The following is a description of a gene set: Mouse Gene Set: GOBP_NEGATIVE_REGULATION_OF_PEROXISOME_PROLIFERATOR_ACTIVATED_RECEPTOR_SIGNALING_PATHWAY Any process that stops, prevents, or reduces the frequency, rate or extent of the peroxisome proliferator activated receptor signaling pathway. species: Mus musculus, and this is the list of marker genes: Stub1, Huwe1, Cyp2j6, Twist1, Paqr3, Plin5, Asxl1